Given this list of marker genes MCCC1, MCCC2, here is a description of the gene set: part of: Diseases of branched-chain amino acid catabolism 3-methylcrotonyl-CoA carboxylase catalyzes the reversible conversion of 3-methylcrotonyl-CoA to 3-methylglutaconyl-CoA, the fourth step in the catabolism of leucine. MCCC is composed of two subunits encoded by MCCC1 and MCCC2. MCCC1 protein is covalently attached to a biotin moiety that is essential for the ATP dependent carboxylation activity, while MCCC2 contributes carboxyltransferase activity. Mutations in either subunit of the enzyme, MCCC1 and MCCC2, are associated with 3-methylcrotonyl-CoA carboxylase deficiency (MCCD), also known as 3-methylcrotonylglycinuria, an autosomal recessive inborn error of metabolism characterized by accumulation and excretion of 3-hydroxyvaleric acid and 3-methylcrotonylglycine. MCCD is the most prevalent organic aciduria with frequencies ~ 1:50,000 but has variable clinical phenotypes. 1-2% of affected individuals are at risk of a severe adverse effect that manifests during the neonatal period with severe neurological impairment while ~10% of affected individuals develop only minor symptoms. Mutations in MCCC1 and MCCC2 have been identified that affect the stability or activity of the alpha or beta subunit, occasionally by compromising the essential biotinylation of the protein. Reactome Pathway: 3-Methylcrotonyl-CoA carboxylase deficiency species: Homo sapiens